Given this list of marker genes DLL1, TOMM22, NUCB2, SCARNA8, RANBP3, GEMIN2, SHISAL2A, LMLN, SNORA54, ZNF780B, TXK, LMO7, KCNQ5, PRKAR1B, RSBN1, TMEM229B, NOG, USP53, ARMCX1, SSBP2, TRAV8-3, HBS1L, ZNF300, EXOSC2, TPST1, AK3, LSM5, AEBP1, GGACT (NCBI Gene Id 87769), GABBR1, AGMAT, CHRM3 (cholinergic receptor muscarinic 3), ZFP3, SREBF1, CYP2U1, EPHX2, ALDH3A2, OSGEPL1, SPATA6 (NCBI Gene Id 54558), SPTLC3, TOM1L2, CLTRN, PCED1A, MRPL16 (mitochondrial ribosomal protein L16), CFP, MEGF6, SYPL1, PAK1, RNF157, UBE2E2, NARS1, NRCAM, RBFA, CLNS1A, ZNF711, CLUAP1, ADPRM, ZNF550, STK26, CCNG1, METTL3, CHMP7, CASP10, PPM1N, ZNF333, BACH2, PPP1R2P1, KCNQ1, GPRASP3, ENTPD6, DPH2, E2F5, DDX28, SH3RF3, ZNF204P, LBH, NT5E, ARHGAP45, PTGR2, SSBP3, CBY1, FBP1, MYC, ALPK1, FECH, RIN3, ZNF414, SNORA5C, PLEKHG4, TCEA3, BBS10, POGLUT3, UBTF, SLC16A10, ZNF470, ACKR3, AK5, PPFIBP2, RRS1, TMEM263 (transmembrane protein 263), C2CD2, ZNF391, CTSO, ZNF248, TSEN2, ZC4H2, SNTG2, MLLT6, FXN, NOC3L, GCDH, SULT1B1, ABRAXAS1, ATL1, CYTH4, MTRES1, C16orf74, METTL21A, CYP2J2, PALS2, RAPGEF6, NBEA, LTA4H, NMNAT3, TACR1, EIF4E, ITGA6, KIAA1586, MACROH2A2, PLXNA2, ANAPC16, MRPL3, GAL3ST4, MOV10, AKR1B1, TLE4, MFSD4A, UMPS, ZKSCAN7, RABEPK, IGF1R, LDLRAP1, ZBTB9 (NCBI Gene Id 221504), ACSS2, ZNF740, TSPAN32, CDCA7L, TRABD2A, GJB6, ALDH5A1, CFAP418, PRNT, PTPRK, RASGRP2, PLCG1, CHAC2, ZNF84, RAD54B, SERTAD2, HLA-DOA, TGS1, AP1M1, ZCCHC7, ENTR1, TMEM19, ARRDC4, ZNF157, KIAA0040, ANGEL1, NR3C2, PFAS, SLC43A2, WDR36, QDPR, OSBPL5, BCKDHB, IQCA1, NDRG2, FARSB, H2AJ, ACTN1, TFB2M, SCOC-AS1, NFE2L2, MRTFA, CSTF2T, FGGY, ZFP2, SPPL2B, FAM229B, FMO4, ARHGEF2, TIMP2, IFI6, MRPL30, CCDC65, FANCF, TCEAL1, SCRN1, here is a description of the gene set: studied in species Homo sapiens Human Gene Set: GSE5542_UNTREATED_VS_IFNG_TREATED_EPITHELIAL_CELLS_24H_DN from publication Sanda C, Weitzel P, Tsukahara T, Schaley J, Edenberg HJ, Stephens MA, McClintick JN, Blatt LM, Li L, Brodsky L, Taylor MW (PMID 16800785) Type I and type II interferons (IFNs) bind to different cell surface receptors but activate overlapping signal transduction pathways. We examined the effects of a type I IFN (IFN-acon1) and a type II iFN (IFN-g1b) on gene experession in A549 cells and demonstrate that there is a common set of genes modulated by both IFNs as well as a set of gene specifically regulated by each, reflecting the activation of different signaling pathways. In particualr, IFN-g induced many more genes of the signaling pathways, apoptosis, and cytokine interactions than did IFN-a. Even with genes induced by both IFNs there were distinctive quantitativive differences in expression. IFN-g1b plays a major role in the induction and regulation of the complement pathway. Previous work has shown a synergistic antivral and antiproliferative effect of type I and type II IFNs in cell culture and in the treament of tumors in mice. We demonstrate that a majority of genes showed and additive effect of IFN-acon1 and IFN-g1b, but a subset of gene is synergistically induced; these incluce ISG10, MX2, OAS2, and other genes known to be involved in the antiviral response, TRAIL (TNFSF10) and caspases involved in apoptosis and chemokine genes RANTES, CXCL10, and CXCL11. Greater than additive transcription of some of these genes in the presence of both IFNs was confirmed by real-time kinetic RT-PCR. Elevated induction of many of these genes may be sufficient to explain the synergistic antiviral and antitumor effects of this combination of IFNS in vivo. Genes down-regulated in epithelial cells (24h): untreated versus IFNG.